Given this list of marker genes Acsl1 (acyl-CoA synthetase long-chain family member 1), Fabp3, Arg1, Oxt, Irs2, Slc36a2, Pla2g3 (phospholipase A2, group III), Akt2, Tnf, Mif, Kmo, Slc6a1, Prkg1, Adora2a, Fis1, Arl6ip5, Arg2, Septin2 (septin 2), Dtnbp1, Fxyd1, Repin1, Ces1c, Trh, Slc43a1, Eprs1, Gabbr1, Htr6, Slc12a2, Npy5r, Pla2r1, Grin2b, Il1rn, Psen1, Ces1e, Ntsr1, P2rx7, Grik1, Abcb11, Ces1g, Slc43a2, Cldn2, Grm7, Erfe, Htr1a, Slc38a3, Grm2, Thbs1 (NCBI Gene Id 21825), Mapk9, Cltrn, Htr1b, Acsl4, Atp5pf, Ace2, Ces1d, Sstr4, Snca, Edn1, Agtr2, Cyp4a32, Avp, Htr2c, Per2, Cyp4a10, Tnfrsf11a, Map2k6, Akt1, Hrh3, Rgs4, Hrh2, Slc38a2, Syk, Ptges, Ces1f, Ces1b, Pla2g10, Agt, Itgb1, Cck (cholecystokinin), Pla2g4a, Arhgef11, Slc38a1, Slc7a5, Nr3c1, Dpysl2, Adora1 (adenosine A1 receptor), Acsl6, Ces1h, Il1b, Avpr1a, Slc17a8, Cyp4a31, Tnfsf11, P2ry2, Acacb, Rab3gap1, Syt4, Acsl5 (NCBI Gene Id 71879), Avpr1b, Lep, Il1a, Arl6ip1, Stxbp1, Rgs2, Abat, Sv2a, Ces1a, Pla2g6, here is a description of the gene set: Any process that modulates the frequency, rate or extent of the directed movement of organic acids into, out of or within a cell, or between cells, by means of some agent such as a transporter or pore. studied in species Mus musculus Mouse Gene Set: GOBP_REGULATION_OF_ORGANIC_ACID_TRANSPORT